The following is a description of a gene set: Mouse Gene Set: GOBP_PYRUVATE_BIOSYNTHETIC_PROCESS studied in species Mus musculus The chemical reactions and pathways resulting in the formation of pyruvate, 2-oxopropanoate., and this is the list of marker genes: Agxt, Pkm, Srr, Hoga1, Pklr, Sds